The following is a description of a gene set: Abnormal erythrocyte adenosine deaminase activity Activity of adenosine deaminase in red blood cells outside the limits of normal. Human Gene Set: HP_ABNORMAL_ERYTHROCYTE_ADENOSINE_DEAMINASE_ACTIVITY species: Homo sapiens, and this is the list of marker genes: RPS29, RPL31, RPL15, RPS27, RPL27, RPS17, RPS15A, GATA1, RPL5, HEATR3, RPL9, RPL11, RPS26, RPS19, ADA, RPL18, RPS7, RPS24, RPL35, TSR2, RPL26, RPS20, RPL35A, RPL8, RPS28, RPS10, ADA2